The following is a description of a gene set: Genes up-regulated in 9.5 days post coitus (dpc) embryos with COMMD1 knockout compared to normal 9.5 dpc embryos. species: Mus musculus Human Gene Set: VANDESLUIS_COMMD1_TARGETS_GROUP_3_UP COMMD1 (previously known as MURR1) belongs to a novel family of proteins termed the copper metabolism gene MURR1 domain (COMMD) family. The 10 COMMD family members are well conserved between vertebrates, but the functions of most of the COMMD proteins are unknown. We recently established that COMMD1 is associated with the hepatic copper overload disorder copper toxicosis in Bedlington terriers. Recent in vitro studies indicate that COMMD1 has multiple functions, including sodium transport and NF-kappaB signaling. To elucidate the function of Commd1 in vivo, we generated homozygous Commd1 null (Commd1(-/-)) mice. Commd1(-/-) embryos died in utero between 9.5 and 10.5 days postcoitum (dpc), their development was generally retarded, and placenta vascularization was absent. Microarray analysis identified transcriptional upregulation of hypoxia-inducible factor 1 (HIF-1) target genes in 9.5-dpc Commd1(-/-) embryos compared to normal embryos, a feature that was associated with increased Hif-1alpha stability. Consistent with these observations, COMMD1 physically associates with HIF-1alpha and inhibits HIF-1alpha stability and HIF-1 transactivation in vitro. Thus, this study identifies COMMD1 as a novel regulator of HIF-1 activity and shows that Commd1 deficiency in mice leads to embryonic lethality associated with dysregulated placenta vascularization. from publication van de Sluis B, Muller P, Duran K, Chen A, Groot AJ, Klomp LW, Liu PP, Wijmenga C (PMID 17371845), and this is the list of marker genes: MATN4, TNNT2, TRIM25, ALPK3, RNASE4, DSG2, TSPAN8, APOC1, LDHA, CGNL1, STARD10, SLC39A5, TM4SF5, RENBP, PLCXD1, ARID3B, MYH7, CLDN6, AMN, BEX4, KRT19, UPP1, SCARB1, CAMSAP3 (NCBI Gene Id 57662), AP1M2, LIN28A, SLC16A3, TPI1, KRT84, CCNG1, SPP2, APRT, GRHPR, TF, PFKL, CLDN2, PDZK1, KCNE3, CYBA, ALDOA, GALK1, REEP6, ITGA3, ADM, PRSS8 (serine protease 8), CA7, PODXL, HKDC1, FAM162A, PKP2, LGALS2, PHLDA2, EZR, CTSV, LY75, CDH1, TAGLN2, AASS, MYO7A, AFP, BNIP3L, LSR, ALDOB, ERO1A, APOA4, HAS2, SPINT1, SNCA, FOLR1, ETV5 (NCBI Gene Id 2119), PLEKHA2, BEX1, SLC13A4 (solute carrier family 13 member 4), FKBP11, APOA2, CBX7, EGLN3, IER3, NHERF1, CCDC198, CTSZ, SHMT2